The following is a description of a gene set: studied in species Homo sapiens Signaling by PDGF Human Gene Set: REACTOME_SIGNALING_BY_PDGF, and this is the list of marker genes: COL4A2, GRB7, SPP1, PIK3R1, NCK1, GRB2, KRAS, NRAS, CRKL, SOS1, STAT3, PTPN12, PDGFB, PIK3R2, STAT6, THBS1, THBS3, PDGFRB, HRAS, COL9A1, PDGFD, SRC, PLCG1 (NCBI Gene Id 5335), THBS4, COL4A5, BCAR1 (NCBI Gene Id 9564), STAT1, COL5A2, FURIN, PDGFA, COL6A6, STAT5B, COL4A1, PDGFC, RASA1, COL6A1, PTPN11, CRK, STAT5A, COL5A3, NCK2, COL5A1, THBS2, PDGFRA, COL9A3, COL4A4, RAPGEF1, COL6A5, COL6A3, COL2A1, COL4A3, COL3A1, COL6A2, PLAT, COL9A2, PIK3CB, PLG, PIK3CA